Given this list of marker genes TUBB2A, CD24, CCNA1, TNIK (TRAF2 and NCK interacting kinase), FOXJ3, COL5A1, TTLL12, PLXNA3, HACD2, NEK2, ENAH, VCAN, here is a description of the gene set: Most gene expression profiling studies of mesothelioma have been based on relatively small sample numbers, limiting their statistical power. We did Affymetrix U133A microarray analysis on 99 pleural mesotheliomas, in which multivariate analysis showed advanced-stage, sarcomatous histology and P16/CDKN2A homozygous deletion to be significant independent adverse prognostic factors. Comparison of the expression profiles of epithelioid versus sarcomatous mesotheliomas identified many genes significantly overexpressed among the former, including previously unrecognized ones, such as uroplakins and kallikrein 11, both confirmed by immunohistochemistry. Examination of the gene expression correlates of survival showed that more aggressive mesotheliomas expressed higher levels of Aurora kinases A and B and functionally related genes involved in mitosis and cell cycle control. Independent confirmation of the negative effect of Aurora kinase B was obtained by immunohistochemistry in a separate patient cohort. A role for Aurora kinases in the aggressive behavior of mesotheliomas is of potential clinical interest because of the recent development of small-molecule inhibitors. We then used our data to develop microarray-based predictors of 1 year survival; these achieved a maximal accuracy of 68% in cross-validation. However, this was inferior to prognostic prediction based on standard clinicopathologic variables and P16/CDNK2A status (accuracy, 73%), and adding the microarray model to the latter did not improve overall accuracy. Finally, we evaluated three recently published microarray-based outcome prediction models, but their accuracies ranged from 63% to 67%, consistently lower than reported. Gene expression profiling of mesotheliomas is an important discovery tool, but its power in clinical prognostication has been overestimated. from publication López-Ríos F, Chuai S, Flores R, Shimizu S, Ohno T, Wakahara K, Illei PB, Hussain S, Krug L, Zakowski MF, Rusch V, Olshen AB, Ladanyi M (PMID 16540645) Top genes associated with unfavorable survival after surgery of patients with epithelioid mesothelioma. Human Gene Set: LOPEZ_MESOTHELIOMA_SURVIVAL_DN species: Homo sapiens